The following is a description of a gene set: Genes containing one or more binding sites for (Mbd1) in their promoter regions (TSS -1000,+100 bp) as identified by GTRD version 20.06 ChIP-seq harmonization. from publication Yevshin I, Sharipov R, Kolmykov S, Kondrakhin Y, Kolpakov F (PMID 30445619) studied in species Mus musculus Mouse Gene Set: MBD1_TARGET_GENES, and this is the list of marker genes: Cacng2, Zfp800, Cenpb, Mgat3, Adam15, Slc30a1 (NCBI Gene Id 98435), Acat2, Klf3, Acvr1b, Trim44, Gnao1, Odf2, Reps1, Got2, Gm22863, H4c3, Ank1, Adgrl3, Nop56, Hrh3, Cimip4, Hey1 (NCBI Gene Id 99610), C230096K16Rik, Uhrf2, Tmt1a, Tle4, Fgf18, Elfn1